The following is a description of a gene set: Any process that stops, prevents or reduces the frequency, rate or extent of extracellular matrix organization. studied in species Mus musculus Mouse Gene Set: GOBP_NEGATIVE_REGULATION_OF_EXTRACELLULAR_MATRIX_ORGANIZATION, and this is the list of marker genes: Tnfrsf1b, Adtrp, Tgfbr3, Dpp4 (dipeptidylpeptidase 4), Cst3 (NCBI Gene Id 13010), Tnfrsf1a, Pparg, Notch1, Emilin1, Antxr1, Chadl, Fap